The following is a description of a gene set: studied in species Homo sapiens Human Gene Set: GSE29618_BCELL_VS_PDC_DN Systems vaccinology has emerged as an interdisciplinary field that combines systems wide measurements and network and predictive modeling applied to vaccinology. Here we used the systems vaccinology approach to study the molecular mechanisms underlying th Genes down-regulated in comparison of B cells versus plasmacytoid dendritic cells (pDC). from publication Nakaya HI, Wrammert J, Lee EK, Racioppi L, Marie-Kunze S, Haining WN, Means AR, Kasturi SP, Khan N, Li GM, McCausland M, Kanchan V, Kokko KE, Li S, Elbein R, Mehta AK, Aderem A, Subbarao K, Ahmed R, Pulendran B (PMID 21743478), and this is the list of marker genes: MYDGF, IL3RA, DPYSL2, SCAMP5, CTSC, SCN9A, DNAJC4, SSR4, SOX4, TM9SF3, MLF2, SELPLG, BTAF1, IRF4, NAGA, ALOX5AP, TLR7, TCF4, EIF4A3, NPC2, ADA (adenosine deaminase), CCDC186, SLC7A11, IRF8, APP, NPC1, MYCL, TBC1D4, CD300A, SCARB2, IFNAR2, UBE2J1, HIGD1A, GPR171, VAMP8, ATG101, ERN1, SLC39A6, IL18R1, ARF3, GUK1, CPT1A, NDRG1, LAMP5, PLP2, CTSB, KRT5 (NCBI Gene Id 3852), CSF2RB, MPZL1, BLTP2, SERPINF1, OTULINL, HSP90B1, BCAP31, DHRS7, NUCB2 (NCBI Gene Id 4925), ENPP2, CUX2, SFT2D2, FLNB, ST3GAL2, MAGED1, SLC38A2, CD2AP, GRSF1, LHFPL2, IRF7, RAB40B, AHNAK2, GPM6B, ASAP2, RIOX2, FKBP2, SEPHS1, SSX2IP, EPHB1, KIF5B, IQGAP2, INPP4A, CCDC88A, LILRA4, UGCG, LILRB4, DNAJC3, EPHA2, BAHCC1, AEBP1, PPIB, CANX, IGF2R, PIAS3, CMKLR1, RPN2, DPP4, LRRC36, PRKCI, SPCS1, ZDHHC17, UCK2, CORO1C (coronin 1C), MAP1A, TPM2, NUS1P3, CRYBG3, PLEK, TRIP10, GLIPR1, PAFAH2, RNF11, ST6GALNAC4, NDUFA4, HDAC2, TAGLN2, UFD1, DAB2, MYL6, TRGV5, HYOU1, MYL12A (NCBI Gene Id 10627), GSN (gelsolin), PTPRE, MGST2, RIMS3, ST14, PLAAT3, ITM2C, FLT3, MYB, POLB, IDH3A, GNA15, TPP1, LGMN, PFKFB2, NUDT1, TNNI2, EGLN3, PTPRS, SLC20A1, TMED10, RRBP1, NREP, GAS6, TM9SF2, SCAMP4 (secretory carrier membrane protein 4), PDIA3, SEC61B, RPN1, PPP1R14B, SCT, CBX6, SEMA3C, CYTH4, TXN, WDR1, MILR1, MRTFA, ADI1, HERPUD1, SRP14, DACH1, DUSP5, FCER1A, GZMB, RNF130, FABP5, PYCARD, KCNK10, MAPKAPK2, MARCHF2, MCM6, ATP13A2, PARK7, GNAQ, PTGDS, AHI1, ASPH, DNASE1L3, SLC7A5, PHB1, RPS6KA2, MAN2B1, GRAMD1B, DSTN, NRP1, TNFRSF21, SH3BP4, TRAF4, GPX1, RGS7, NECTIN1, RUNX2, SEMA4C, PHEX, ETV6, HHAT, CUEDC1, MLEC